Given this list of marker genes Syt1, Stx1a, Slc5a7, Rab3a, Ppfia2, Tspoap1, Cplx1 (NCBI Gene Id 12889), Ppfia3, Vamp2, here is a description of the gene set: This event has been computationally inferred from an event that has been demonstrated in another species.<p>The inference is based on the homology mapping from PANTHER. Briefly, reactions for which all involved PhysicalEntities (in input, output and catalyst) have a mapped orthologue/paralogue (for complexes at least 75% of components must have a mapping) are inferred to the other species. part of: Neurotransmitter release cycle species: Mus musculus electronically inferred by orthology from the curated human pathway Reactome Pathway: Acetylcholine Neurotransmitter Release Cycle